Given this list of marker genes RHOA, GJA1, SALL1, HOXD13, CDH3, CCNQ, SMO, here is a description of the gene set: 3-4 toe syndactyly studied in species Homo sapiens Human Gene Set: HP_3_4_TOE_SYNDACTYLY Syndactyly with fusion of toes three and four.